Given this list of marker genes DGUOK, PNP, APRT, AMPD3, ADSS1, ADSL, AMPD1, ADK, NAPRT, PRTFDC1, DCK, AMPD2, PGM2, HPRT1, ADA, MTAP, here is a description of the gene set: species: Homo sapiens Any process that generates a purine-containing compound, any nucleobase, nucleoside, nucleotide or nucleic acid that contains a purine base, from derivatives of them without de novo synthesis. Human Gene Set: GOBP_PURINE_CONTAINING_COMPOUND_SALVAGE